The following is a description of a gene set: studied in species Homo sapiens The presence of a neoplasm of the gallbladder. Neoplasm of the gallbladder Human Gene Set: HP_NEOPLASM_OF_THE_GALLBLADDER, and this is the list of marker genes: PSAP, SEMA4D, ARSA, MST1, TCF4, GPR35